The following is a description of a gene set: A protein complex that functions as a phospholipid-translocating P-Type ATPase. Human Gene Set: GOCC_PHOSPHOLIPID_TRANSLOCATING_ATPASE_COMPLEX studied in species Homo sapiens, and this is the list of marker genes: ATP10D, ATP11B, ATP10A, ATP10B, ATP8A2, ATP11A, ATP11C, ATP8B2, TMEM30B, ATP8B3, ATP8B4, TMEM30A, ATP8A1, ATP8B1